The following is a description of a gene set: from publication Lake BB, Chen S, Hoshi M, Plongthongkum N, Salamon D, Knoten A, Vijayan A, Venkatesh R, Kim EH, Gao D, Gaut J, Zhang K, Jain S (PMID 31249312) species: Homo sapiens Human Gene Set: LAKE_ADULT_KIDNEY_C16_COLLECTING_SYSTEM_PRINCIPAL_CELLS_CORTEX, and this is the list of marker genes: SLC8A1, GLS, COBLL1, PPP1R9A, PRKG1, ANK3, MECOM, SLC38A1, ERC1, GLIS3, PDE1A, TRAPPC9, CADPS2, KCTD8, DLG2, ARID1B, SH3RF1, KCNIP4, FYB2, FER, BTBD9, FNDC3A, PDE7B, NDRG1, MACC1, RALBP1, COL4A5, MTR, NFAT5, NR2F2-AS1, PKHD1, THSD4, AKT3, STARD13, RAD51B, GAREM1, TMTC2, BMPR1B, SSH2, BRAF, PCCA, FTX, ARB2A, NLK, ST6GAL1, MAN1A1, SCN2A, DANT2, BCAS3, PWRN1, MYO1E, CD2AP, PRKCA, AQP2, TGFBR1, FRAS1, PTPN13, ZFAND3, THRB, LINC01482, RBBP8, AHI1, PIK3C2G, XIST, GRIP1, TRPS1, RALYL, SCIN, TOP6BL, ADAMTS9-AS2, SIK2, ADK, HSD11B2, WSB1, RABGAP1L, THSD7A, TEX41, PTH2R (NCBI Gene Id 5746), TOX3, TRPM3, KSR2, SYTL2, SDK1, TANC2, BAZ2B, KCNJ16 (potassium inwardly rectifying channel subfamily J member 16), MACROD2, IMMP2L, MPPED2 (NCBI Gene Id 744), BABAM2, ATXN1, FHOD3, SPAG16, NLGN1, RBPMS, AFF1, FNDC3B, PRKAG2, SIK3, MBD5, SMYD3, LIMCH1 (LIM and calponin homology domains 1), KAZN, SNHG14, CDK6, SMARCA2, PDE10A (phosphodiesterase 10A), PAPPA, SCMH1, PTBP3, LAMB1, NFIB, PTK2, PDE4D, LRBA, ARL15 (ADP ribosylation factor like GTPase 15), REV3L, NBEA, PLCL2, PDE8A, ROCK2 (Rho associated coiled-coil containing protein kinase 2), MYH10, MAML3, WWTR1, GATA3, CCSER1, DCDC2, MIR99AHG, AGBL4, FAF1, MAPK10, NR3C2, EPB41L4A, ABTB2, SAMD12, MAGI3, PRKN, NAALADL2, MED13L, TOX (thymocyte selection associated high mobility group box), MYO10